The following is a description of a gene set: species: Homo sapiens Human Gene Set: GENTILE_UV_RESPONSE_CLUSTER_D8 from publication Gentile M, Latonen L, Laiho M (PMID 12907719) DNA damage caused by UV radiation initiates cellular recovery mechanisms, which involve activation of DNA damage response pathways, cell cycle arrest and apoptosis. To assess cellular transcriptional responses to UVC-induced DNA damage we compared time course responses of human skin fibroblasts to low and high doses of UVC radiation known to induce a transient cellular replicative arrest or apoptosis, respectively. UVC radiation elicited >3-fold changes in 460 out of 12,000 transcripts and 89% of these represented downregulated transcripts. Only 5% of the regulated genes were common to both low and high doses of radiation. Cells inflicted with a low dose of UVC exhibited transcription profiles demonstrating transient regulation followed by recovery, whereas the responses were persistent after the high dose. A detailed clustering analysis and functional classification of the targets implied regulation of biologically divergent responses and suggested involvement of transcriptional and translational machinery, inflammatory, anti-proliferative and anti-angiogenic responses. The data support the notion that UVC radiation induces prominent, dose-dependent downregulation of transcription. However, the data strongly suggest that transcriptional repression is also target gene selective. Furthermore, the results demonstrate that dose-dependent induction of cell cycle arrest and apoptosis by UVC radiation are transcriptionally highly distinct responses. Cluster d8: genes progressively down-regulated in WS1 cells (fibroblast) through 18 h after irradiation with high dose UV-C., and this is the list of marker genes: PPP1R12A, MAPK14, HNRNPH3, SLC7A6, IRS1, ZCCHC24, STK24, SQLE, RBM15B, REV3L, HMGN4, TOP2A, MARCKS, NACC2, SPRED2, JUN, PPID, MT1X, STK38, THAP11, HEG1, FYN, CBX3, CDYL, TSPAN5, ARHGEF7 (NCBI Gene Id 8874), PARP1, NREP, NR2F2, INSIG1, TWIST1, TAB2, MN1, HIVEP2, YY1, EMP1, HMGCR